Given this list of marker genes Vegfa, Hras, Rasa1, Prkca, Pdpk1, here is a description of the gene set: This event has been computationally inferred from an event that has been demonstrated in another species.<p>The inference is based on the homology mapping from PANTHER. Briefly, reactions for which all involved PhysicalEntities (in input, output and catalyst) have a mapped orthologue/paralogue (for complexes at least 75% of components must have a mapping) are inferred to the other species. part of: VEGFA-VEGFR2 Pathway electronically inferred by orthology from the curated human pathway Reactome Pathway: VEGFR2 mediated cell proliferation species: Mus musculus